Given this list of marker genes Serping1, Cotl1, Crip2, H2-Q6, Tle5, Esam, Lgals1, Rpl13a, Ebf1, Ywhae, Ier2, C1qa, Gnb1, Cd74, Hexb, Cfl1, Krt14, Krt15, Sfn, Atf4, Rbm26, Dpt, Snrpc, Mark2, H2-K1, Mycbp2, Sparc, Jund, Sp140l2, Dpysl2, Lyz2, Fus (fused in sarcoma), Sqstm1, Ptpn1, Cope, Kdm6b, Eng, Tmem160, Junb, Vps37b, Zfp36, C1qb, Oaz1, Sp140l1, Eif1, Apoe, Frat1, Srsf2, Dusp5, Bsg, Crlf2 (cytokine receptor-like factor 2), Tomm6, Gsn, Abi3, Arhgdia, Drap1, Dcn, Edem1, Cd79a, H3f3a, Ssbp4, Mbp, Cst3, Anxa2, Fos, Sod1, Tgtp2, Klf13, C1qc, Tmsb10, Csf1r, Gstm1, S1pr4, Tmed9, here is a description of the gene set: Mouse Gene Set: TABULA_MURIS_SENIS_MESENTERIC_ADIPOSE_TISSUE_B_CELL_AGEING from publication Tabula Muris Consortium (PMID 32669714) species: Mus musculus